Given this list of marker genes GRB2, TNFRSF14, PTPN6, BTLA, PTPN11, here is a description of the gene set: Reactome Pathway: Co-inhibition by BTLA part of: Regulation of T cell activation by CD28 family studied in species Homo sapiens BTLA (B and T Lymphocyte Attenuator) is a co-inhibitory receptor that plays a crucial role in regulating immune responses, maintaining immune homeostasis, and preventing autoimmunity. BTLA interacts with its ligand, HVEM (Herpesvirus Entry Mediator), a member of the tumor necrosis factor receptor (TNFR) family. Upon engagement with HVEM, BTLA recruits the Src homology region 2 domain-containing phosphatases SHP-1 and SHP-2 to its cytoplasmic tail. These phosphatases dephosphorylate key signaling molecules downstream of the T cell receptor (TCR), effectively dampening TCR-mediated signaling and inhibiting T cell activation.<br>This signaling pathway is essential for modulating the immune response, particularly in maintaining peripheral tolerance and preventing the overactivation of T cells that can lead to autoimmune diseases. BTLA is expressed on various immune cells, including T cells, B cells, and dendritic cells, and it functions similarly to other immune checkpoint molecules like CTLA-4 and PD-1, but it has unique structural and functional properties.<br>BTLA's interaction with HVEM also influences the function of other immune cells. For instance, HVEM is expressed on many cell types, including T cells, B cells, and myeloid cells, and its interaction with BTLA can modulate the immune response in a context-dependent manner. This complex interplay is crucial for fine-tuning immune responses and ensuring that immune activation is appropriately regulated.